The following is a description of a gene set: Human Gene Set: GOBP_FRUCTOSE_6_PHOSPHATE_METABOLIC_PROCESS studied in species Homo sapiens The chemical reactions and pathways involving fructose 6-phosphate, also known as F6P. The D-enantiomer is an important intermediate in glycolysis, gluconeogenesis, and fructose metabolism., and this is the list of marker genes: PFKL, FBP1 (NCBI Gene Id 2203), FBP2, HK1, HK3, GPI, MPI, GFPT2, PFKP, TALDO1, NFE2L1, GFPT1, HK2, PFKM